The following is a description of a gene set: This event has been computationally inferred from an event that has been demonstrated in another species.<p>The inference is based on the homology mapping from PANTHER. Briefly, reactions for which all involved PhysicalEntities (in input, output and catalyst) have a mapped orthologue/paralogue (for complexes at least 75% of components must have a mapping) are inferred to the other species. part of: Death Receptor Signaling Reactome Pathway: TNF signaling species: Mus musculus electronically inferred by orthology from the curated human pathway, and this is the list of marker genes: Mib2, Bag4, Ubb (NCBI Gene Id 22187), Tnfrsf1a, Fadd, Casp8, Sppl2a, Rack1, Sppl2b, Otud1, Tab1, Tab2, Clip3, Usp4, Birc3, Cyld (NCBI Gene Id 74256), Optn, Tab3, Tnfaip3, Ikbkb, Rps27a, Ube2d1, Traf1, Tnf, Spata2, Ulk1, Usp21, Tradd, Smpd2 (sphingomyelin phosphodiesterase 2, neutral)